The following is a description of a gene set: Encephalopathy Encephalopathy is a term that means brain disease, damage, or malfunction. In general, encephalopathy is manifested by an altered mental state. Human Gene Set: HP_ENCEPHALOPATHY species: Homo sapiens, and this is the list of marker genes: CDK19, MDH1, CCDC88A, MT-CO3, MT-CO2, GALT, STAT2, ACOX1, WDR45, RNASEH2B, MPV17, CPT2, CLTC, COQ2, TRAK1, CNKSR2 (NCBI Gene Id 22866), NEXMIF, ATP1A2, TBC1D24, ATAD3A, TWNK, BCS1L, ARX, RNF13, IRF5, BOLA3, MT-TV, NDUFA1, DPM1, SLC35A1, KCNQ5, CRLS1, TNPO3, TUFM, GABRB3, TH (tyrosine hydroxylase), TBCK, SH2D1A, MTHFR, RNU4-2, STXBP1, HSD17B10, CHD2, NDUFS6, SLC2A1, ATP5F1E, TRAPPC12, ATP5F1D, GRIN1, D2HGDH, UNC80, NDUFS2, PNKP, WWOX, HIBCH, JAK2 (Janus kinase 2), TMEM126B, FCSK, SLC25A12, ATAD1, TK2, CPT1A, CACNA1E, NAXD, HTRA1, SEMA4D, GABRG2, MT-ND4, ITPA, SCN8A, TSEN54, FOXG1, MYRF, MMACHC, AFF3, CHKA, NDUFB11, NDUFAF5, FOCAD, MT-ND3, FGF12, NDUFB9, MST1, IBA57, ATG7, POLG, CAD, KCNT1 (potassium sodium-activated channel subfamily T member 1), HMGCS2, CELF2, NDUFB3, PTPN23, SLC25A1, FBXO28, DNM1, PNPT1, AP3B2, DOCK7, PLCB1, DGUOK, NDUFB10, BSCL2 (NCBI Gene Id 84753), TGFB1, MPC1, COX15, SLC35A2, STAG1, MED23, RNH1, PCCB, MT-ND2, SERAC1, CYC1, GABRA1, PAFAH1B1, NRXN1, CACNA1B, KCNA2, ACY1, MAPK10, DENND5A, IL12A, ROGDI, KCNQ2, ADAM22, PARS2, SLC6A9, MEF2C, MT-ND1, COQ5, CLPB, TIMMDC1, DPM2, ATP5F1A, TBCD, TRIT1, TSFM, NDUFAF8, GNAO1, SIK1, ATP6V1A, ARHGEF9, NAPB, MAST3, DBR1, FBLN1, PHACTR1, NDUFV1, SCN1A (NCBI Gene Id 6323), NAXE, COQ9, MT-CYB, ALG9, ZNHIT3, SCN3A, MT-TF, DNM1L, KCNB1, AARS1, NDUFAF4, NDUFA2, ZNFX1, YWHAG, DALRD3, SUCLG1, TNFSF15, AP2M1, GABRA5, SLC52A3, MT-TL1, TCF4, F5, SLC19A3, GABRA2, KMT2E, KCNA1, SLC12A3, NDUFS1, HADH, SYNGAP1, OTC, SCN1B, CUX2, SLC25A15, MT-TK, FBP1, NEUROD2, COQ4, SYNJ1, HCN1, COG8, UBA5, XIAP, HNRNPU (NCBI Gene Id 3192), COX16, MMEL1, MT-TS2, FOXRED1, HMGCL, FADD, FBXL4, GLS, DPAGT1, GLYCTK, NBAS, SLC1A2, GRIN2B, NADK2, NDUFA11 (NADH:ubiquinone oxidoreductase subunit A11), NECAP1, MT-ND6, KCNC2, GPR35, GCDH, NOTCH3, DCX, TSPOAP1, SCO2, UGDH, FZR1, CARS2, RINT1, SMARCAL1, KCNT2, ASNS, CALR, EIF2AK3, IL12RB1, SLC25A20, MT-TC, AMACR, GABRB1, GABRB2, DHDDS, MECP2, LIAS, PIGP, SMC5, NDUFV2, PIGA, CLCN4, CYFIP2, GLDC, SLC25A13, TIMM50, CLCNKB, SQOR, NUBPL, CLP1, GRIN2A, CPLX1, TRAF3, SLC32A1, NDUFS7, GRIN2D, ATP5MK, RANBP2, MT-CO1, GALC (NCBI Gene Id 2581), SPTAN1, MT-TW, ACAD9, HECW2, SUCLA2, UGT1A1, POU2AF1, POLR1A, NFU1, MT-TH, MT-TQ, HNRNPR, CACNA1A, TBCE, MDH2, NDUFA6, NDUFS4, FRRS1L, SLC13A5, TPK1, ZNF668, ATPAF2, LIPT2, MT-ND5, TULP3, ACTL6B, TRIM8, LRPPRC, NDUFS3, CNPY3, NSF, NDUFAF1, PIGQ, CA5A, PSAP, EEF1A2, ARV1, PCK1 (phosphoenolpyruvate carboxykinase 1), GPT2, NDUFAF2 (NADH:ubiquinone oxidoreductase complex assembly factor 2), MT-ATP6, SLC22A5, TREX1, GRM7, TMEM70, PNPO, PPP3CA, GUF1, LYRM7, PCCA, KCNH5, CACNA2D2, CACNA2D1, ALMS1, GABBR2, SCN2A, PACS2, DLD, SLC9A6, ACSF3, ETHE1, SLC6A1, KYNU, DMXL2, SPIB, NTRK2, GLUL, NDUFAF3, SLC38A3, PRNP, ACADS, GBA1 (glucosylceramidase beta 1), SZT2 (SZT2 subunit of KICSTOR complex), NUS1, GRIK2, PMPCB, NAGS, ST3GAL3, MT-ATP8, NDUFS8, ALDH4A1, SERPINI1, RNASEH2C, SLC25A22, ATP1A3, RYR1, CDKL5, CASK